Given this list of marker genes EID1, GM2A, SLFN12, DESI1 (NCBI Gene Id 91610), SERINC3, EVL, MYO7A, CYFIP2, SLC66A3, TMSB10, TMEM229B, ALPL, GAB1, GBP2, BLK, GIMAP4, XRCC6, CD74, EMP1, here is a description of the gene set: species: Mus musculus Genes down-regulated in pre-B lymphocytes upon Cre-Lox knockout of E2A. from publication Greenbaum S, Lazorchak AS, Zhuang Y (PMID 15310760) The transcription factors encoded by the E2A gene have been shown to play essential roles in the initiation and progression of lymphocyte development. However, there is still a lack of comprehensive understanding of E2A downstream genes in B-cell development. We previously developed a gene tagging-based chromatin immunoprecipitation (ChIP) system to directly evaluate E2A target genes in B-cell development. Here, we have improved this ChIP strategy and used it in conjunction with microarray analysis on E2A-deficient pre-B-cell lines to determine E2A target genes in lymphocyte development. Both microarray data and ChIP studies confirmed that E2A directly controls IgH gene expression. The microarray assay also revealed genes that were significantly up-regulated after E2A disruption. ChIP analysis showed that E2A was most likely to be directly involved in repression of some of these target genes such as Nfil3 and FGFR2. An inducible E2A reconstitution system further demonstrated that E2A-mediated repression of Nfil3 and FGFR2 was reversible. Collectively, these findings indicate that E2A is a positive regulator for one set of genes and a negative regulator for another set of genes in developing B lymphocytes. Human Gene Set: GREENBAUM_E2A_TARGETS_DN